Given this list of marker genes DPP10, IL6ST, ZNF385B, UTP25, RHOU, ZNF682, PUM2, ANK3, KIAA1671, SNAPC1 (NCBI Gene Id 6617), RNF169, PRELID3B, SLC25A36 (NCBI Gene Id 55186), HAVCR2, PPP4R2, DTNA, NOL4, GMCL1, FRMD3, FAM32A (NCBI Gene Id 26017), STK35, DLG3, SLC9B1, ZBTB20, ZNF418, PUM1, GABPB2, TSHZ3, HEXIM1, WDR48, SH3TC2, SEMA5A, INTS8, SMG7, DRG2, UBE2W, GDA, CHD1, CREBZF, CHST15, ZMYND8, MARCHF8, UFM1, ZNF697, ANP32E, DCHS2, TMX1 (NCBI Gene Id 81542), AP4S1, ZRANB3, MTMR4, THAP12, ARPC3, ZFP36L1, VPS50, CCDC6, TEX19, BRWD1, CREG1, ABITRAM, B3GALNT2, BCL2L13, EPHB1, ZDHHC20, CALML4, MTMR10, ZNF761, FBP2, PABPN1, TRIQK, GNA14, SLF2, FERRY3 (NCBI Gene Id 57200), GRIK2, NEU3, PLEKHH1, SH3BGRL2, PSMC6, DDX55, NUFIP2, PTP4A1, NCKAP5, RARB, SGTB, SCN1B, SLC49A4 (NCBI Gene Id 84925), RAB2A, CTSS, CACNA2D2, PLCH1, FBXW11, SLC5A12, CHST11, GPATCH2L, SPRY4, TXNDC8, GLIPR1, LRP8, LAMC1, C11orf87, RNF217, DDX4, FCGR1A, PATE1, JPH3, E2F3 (NCBI Gene Id 1871), EGLN1, STARD7, PCNX1, EML4, MAGI3 (NCBI Gene Id 57725), TSLP, PPP1R12A, JADE1, DIO2, MFSD14B, GNPTAB, C8orf33, NCALD, DPY30 (dpy-30 histone methyltransferase complex regulatory subunit), SIPA1L2, METTL21A, C11orf58, MRTFB, CDH4, CARD8, FAN1, KATNAL1, RAP2A, MYSM1, TTC39B, WDR3 (NCBI Gene Id 10885), OPCML, ZC3H14, GALNT15, LRTM2, CLCN3, ZNF148, DCDC1, BMPR2, PSTK, SNRNP27, NRIP1, LRP6, CAP2, MAP1B, TMEM135, S100PBP, PCDH15, PRKG2, FHIP2A, ZW10, CCNA2, RNF222, CLTC, PTPRT, GBX2, HOOK3, SUPT20H, PRKACB, SUCO, MRRF, PIK3CG, EML5, TMEM168, BTRC, TNFSF10 (TNF superfamily member 10), TECTB, CCDC13, PTPN12, RALGPS2, CD22, PSMB11, IFI44, GABRB3, MIER1, SRGAP2, CDK2AP1, SPATA6, MTOR, GLI2, CHML, EXD2 (exonuclease 3'-5' domain containing 2), IGFBP7, TNFAIP8L2, CCL16, KLHL2, ARID5B, NDFIP2, LYRM9, DENND1B, ATG101, GPRIN1, SBF2 (NCBI Gene Id 81846, SET binding factor 2), ANKS1B (NCBI Gene Id 56899), RBM12, DDX6, PROX2, PRKN, FCGR1BP, CALD1, C1orf21, TNRC6B, AKAP10, NR3C1, SNX19, BCAS1, STK32A, EOGT, CYBB, ANKRD50, BTG1, ITGB5, SRXN1, EEIG2, SUMO1, PHF2 (NCBI Gene Id 79448), TBL1XR1, SSTR3, MET, RIT2, ZNF81, MIGA1, IER5, ARHGAP21, UBR5, ATP2B1, KLHL14, TRDMT1, MALT1, ATRX, USP28, ELAVL3, SMIM13, DNAH12, PTBP3, SLC16A14 (solute carrier family 16 member 14), GPR158, BROX, C5orf63, GHITM, MARVELD3, MYOCD, MINAR1, KDELR1, IFRD2, NMNAT2, AMOTL2, YTHDC1, CSNK1A1, S1PR3, MTAP, RNF41, PYROXD1 (NCBI Gene Id 79912), EEF1E1, DIXDC1, WDR41, SORL1, RAB14, TCP11L2, RALGAPA2, here is a description of the gene set: Genes predicted to be targets of miRBase v22 microRNA hsa-miR-3182 in miRDB v6.0 with MirTarget v4 prediction scores > 80 (high confidence targets). from publication Chen Y, Wang X (PMID 31504780) studied in species Homo sapiens Human Gene Set: MIR3182